The following is a description of a gene set: The radially directed movement of a cell along radial glial cells in the hindbrain. Radial migration refers to a directed movement from the internal ventricular area to the outer surface of the hindbrain. Mouse Gene Set: GOBP_HINDBRAIN_RADIAL_GLIA_GUIDED_CELL_MIGRATION species: Mus musculus, and this is the list of marker genes: Dab1, Lrp6, Cul5, Ctnna2, Itgb1 (integrin beta 1 (fibronectin receptor beta)), Atp1b2, Arl13b, Rere, Flna, Socs7, Lef1, Cend1, Ulk1, Rbfox2, Rnf7